The following is a description of a gene set: studied in species Mus musculus Mouse Gene Set: REACTOME_SUMO_IS_PROTEOLYTICALLY_PROCESSED SUMO is proteolytically processed, and this is the list of marker genes: Sumo2, Senp2, Senp1, Senp5, Sumo1, Sumo3